Given this list of marker genes SCO2, ADAR, NUP62, FARS2, PRNP, NUP54, ABCB7, VRK1, PDHA1, MT-ATP6, LONP1, here is a description of the gene set: Basal ganglia gliosis Human Gene Set: HP_BASAL_GANGLIA_GLIOSIS Focal proliferation of glial cells in the basal ganglia. species: Homo sapiens